Given this list of marker genes SMARCD2, LRRN3 (leucine rich repeat neuronal 3), SUGP2, NCKAP5L, PRPF38B, ITGAV, METTL25B, PRP4K, SNRNP48, REXO5, ADORA2A, KIAA0040, KLHL17, POU5F2, RPL37A, SEMA6D, SUGCT, ARNT, MORF4L2, WSCD2, UBL5, RBM4B, KXD1 (KxDL motif containing 1), UVSSA, NDUFA5, RNF168, ANAPC5, SNRPG, DTX2, SNHG8, PRKD1, TNIK, ZNF329 (zinc finger protein 329), TTC3, NFIA, NFAT5, CCNT2, SEMA4C, MYL6B, RSAD1 (radical S-adenosyl methionine domain containing 1), ABCB11, TMEM198, DCBLD1, TTLL3, NPY4R, RPS27, NSMF, PRPF19, PABPN1, SLC17A9, GBP6, TMEM158, ZNF436, KRTAP2-4, UBN2, MCF2L, CAMKK2, NISCH, SSH1, DEK, TNK2, SDC3, NAA38, ASIC1, F13A1, SLC22A17, CCDC171, SLC16A14, WDR48, TBC1D1, UPF3B, HACD3, FAM8A1, UBXN2B, TSHZ1, CLDN12, CCNL2 (cyclin L2), SHISA4, DAPK1 (NCBI Gene Id 1612), SON, MYH4, GET4, AAK1, ZRANB1, HEG1, RP1L1, ANKRD23, FIRRE, ZDHHC9, ERGIC1, ARMCX1, SNHG3, TEKTIP1, SLC7A10, MTX3, ZBED6, SUCO, MAP1LC3A, ROBO3, NDUFA2, VPS37C, ANKRD39, RPL23, CES3, LHCGR, TTC19, SEC11C, ADPGK, CWC22, RINL, NRF1 (nuclear respiratory factor 1), PNISR, LYRM9, NSG1, TFAP2A, CASQ2, GUCY1A2, NIPAL4, ADARB1, STRN4, ADAMTS20, CCDC62, SERF2, HMGN3 (high mobility group nucleosomal binding domain 3), FBXL19, PIGO, DCTN1, SOCS7, LRRC19 (leucine rich repeat containing 19), TRMT13, NPC2, VAPB, CSTB, HIF3A, TAMALIN, TMEM258, MYO1D, ATP8B1, MSS51 (MSS51 mitochondrial translational activator), FYCO1, DVL1, MXD4, STX1A, MAN2C1, TSC22D1, PLAU, JMJD7-PLA2G4B (JMJD7-PLA2G4B readthrough), GUCA1B, POLDIP3, ROMO1, YPEL2, DOP1A, PXN, ZMYM3, GTPBP2, INTS6L, TRIM69, ARL6IP5, CIART, TTC28, STXBP4, EYA1, VAPA, CXCL2, RASAL1, SLC25A36 (NCBI Gene Id 55186), TOM1, MEP1A, SLC4A9, URI1, DOCK4, IGIP, BMPR2, ENPEP (NCBI Gene Id 2028), CCDC186, CSNK1D, CAB39L (calcium binding protein 39 like), ANGPTL1, ZFR2, PDE1B, GAREM1, NFKBIA, CDK16, HMBOX1, MARVELD1, DDHD1, AMPD2, DDIT4, KRT76 (keratin 76), PFKFB2, RGS16, CCDC40, SLC7A1, H2BC18, SLC38A10, NDUFAF8, YTHDC1, SETD1B, SNORD104, here is a description of the gene set: Human Gene Set: GSE25123_IL4_VS_IL4_AND_ROSIGLITAZONE_STIM_MACROPHAGE_DAY10_DN from publication Szanto A, Balint BL, Nagy ZS, Barta E, Dezso B, Pap A, Szeles L, Poliska S, Oros M, Evans RM, Barak Y, Schwabe J, Nagy L (PMID 21093321) Conditional macrophage-specific PPARg knockout mice were generated on C57Bl/6 background by breeding PPARg fl/- (one allele is floxed, the other is null) and lysozyme Cre transgenic mice. PPARg and IL-4 signaling was analyzed on bone marrow-derived macrophages. Bone marrow of 3 mice per group was isolated and differentiated to macrophages with M-CSF (20 ng/ml). 20 ng/ml IL-4 was used to induce alternative macrophage activation and 1 uM Rosiglitazone (RSG) was used to activate PPARg. From each mouse 4 samples were generated: 1. M-CSF, 2. M-CSF+RSG, 3. IL-4 and 4. IL-4+RSG. All compounds were added throughout the whole differentiation process, and fresh media was added every other day. Control cells were treated with vehicle (DMSO:ethanol). After 10 days, RNA was isolated and gene expression profiles were analyzed using Mouse Genome 430 2.0 microarrays from Affymetrix. species: Homo sapiens Genes down-regulated in wildtype bone marrow-derived macrophages treated with IL4: control versus rosiglitazone.